The following is a description of a gene set: Mouse Gene Set: GOMF_AMINO_ACID_PROTON_SYMPORTER_ACTIVITY studied in species Mus musculus Enables the transfer of a solute or solutes from one side of a membrane to the other according to the reaction: amino acid(out) + H+(out) = amino acid(in) + H+(in)., and this is the list of marker genes: Slc36a3, Slc25a18, Slc36a1, Slc25a22 (NCBI Gene Id 68267), Slc36a2